The following is a description of a gene set: Human Gene Set: LI_ESTROGENE_LATE_E2_RESPONSE_DN As one of the most successful cancer therapeutic targets, estrogen receptor-alpha (ER/ESR1) has been extensively studied over the past few decades. Sequencing technological advances have enabled genome-wide analysis of ER action. However, comparison of individual studies is limited by different experimental designs, and few meta-analyses are available. Here, by ingesting large amount of E2-related transcriptomic data sets in breast cancer cell lines, we identified gene expression changes across 66 RNA-seq and 80 microarray experiments based upon the E2-induced fold change in gene expression. Among the 146 merged transcriptomic datasets, 27 different time points were annotated spanning from 5 minutes to 600 hours of estrogen stimulation. We separated all the comparisons into three signatures of duration: EstroGene_Early (≤6 hours, n = 58), EstroGene_Mid (6-24 hours, n = 44) and EstroGene_Late (≥ 24 hours, n = 44). Upregulated and downregulated genes present in the top 10th percentile of regulated genes in each individual study, and consistently present across at least 50% of studies at each time period, were extracted from each signature (early, mid, and late) and intersected accordingly. We identified 165, 59 and genes representing early, mid, and late estrogen response signatures, respectively. from publication Li Z, Li T, Yates ME, Wu Y, Ferber A, Chen L, Brown DD, Carroll JS, Sikora MJ, Tseng GC, Oesterreich S, Lee AV (PMID 37272757) species: Homo sapiens High confident estrogen down-regulated genes in early treatment duration (≥ 24 hours) in breast cancer cells merged from 44 NGS datasets-based comparisons (10% topmost down-regulated genes and consistent in at least 40% comparisons)., and this is the list of marker genes: FAM83A, FBXO32, UPK2, KRT24, ABCC5, ITGB6, SERHL2, RTL5, ST3GAL1, EMP1, PHEX, PIK3IP1, GABBR2, LXN, PRKG1, KRT4, H2AC6, ACKR3, VGLL1, SSPOP, CTNND2, WNT11, H4C8, TCP11L2, UPK1A, ST6GAL1 (ST6 beta-galactoside alpha-2,6-sialyltransferase 1), MMP16, PGM5, RFTN1, GRB14, CXCR4, PVALB (NCBI Gene Id 5816), PCDH7, ACHE, HDAC9, EFNB2, RND1, ABCA1, ANTXR2, DKK1, KRT81, NTN4, AQP3, SLIT2 (slit guidance ligand 2), DAB2, PLEKHF1, UNC5C, DLX2, TSPAN1, MAB21L4, P2RX2, CEMIP, GRM4, SEMA6D, CAMK2N1, IGDCC3, EPAS1, NBEA, CRYM, ENTPD3, PALMD, KLHDC7A, CLMN, CSTA, FBN2, H2BC8, HPX, C1orf115, COL28A1, HOPX, PMP22, FAM110B, MYO1B, LDLRAD4, FPR3, IGFBP3, CYP4B1, CLIP4, TMEM86A, CA5B